Given this list of marker genes Slc26a4, Slc26a1, Slc26a7, Slc26a2, Slc26a11, Slc26a6, Slc26a9, here is a description of the gene set: part of: SLC-mediated transport of inorganic anions species: Mus musculus Reactome Pathway: Inorganic anion exchange by SLC26 transporters This event has been computationally inferred from an event that has been demonstrated in another species.<p>The inference is based on the homology mapping from PANTHER. Briefly, reactions for which all involved PhysicalEntities (in input, output and catalyst) have a mapped orthologue/paralogue (for complexes at least 75% of components must have a mapping) are inferred to the other species. electronically inferred by orthology from the curated human pathway